The following is a description of a gene set: species: Homo sapiens Bending or curvature of a finger toward the ulnar side (i.e., away from the thumb). The deviation is at the metacarpal-phalangeal joint, and this finding is distinct from clinodactyly. Ulnar deviation of finger Human Gene Set: HP_ULNAR_DEVIATION_OF_FINGER, and this is the list of marker genes: WNT7A, CRKL, CHRNG, CD96, TGDS, HOXA13, SLC26A2, MYMK, TNNI2, PAX3, MYMX, TBX22, BMPR1B, COG1, TNNT3, HOXD13, MYH3, TPM2, RAB3GAP1, FBN2, HRAS, TBX5, ANKRD11, MAPK1, LIFR, PTRH2, SHOX, TRAF7, GDF5, DHCR7, SALL1, DACT1, NALCN, RAB3GAP2, MYBPC1, BCR, BMP2